Given this list of marker genes MCEE, ACSS2, ACOT9, ACSS1, THNSL2, ACSM1, PCK1, CRAT, PCK2, PCCB, ACOT4, MMUT, PCCA, TYRP1, OXSM, PHYH, ACADS, here is a description of the gene set: The chemical reactions and pathways involving a short-chain fatty acid. A short-chain fatty acid has an aliphatic tail containing fewer than 6 carbons. Human Gene Set: GOBP_SHORT_CHAIN_FATTY_ACID_METABOLIC_PROCESS studied in species Homo sapiens